Given this list of marker genes CENPH, WASF1, EBF2, GNS, CXCR4, ATXN3, PLPPR1, MAP4, DENND4C, PIK3R3, MACF1, ZFAND4, SCAI, ZEB1, BBS5, EZR, FBXO22, IFT81, GPAM, NNT, TMEM245, ZNF658, MAP3K2, HERC4, ZNF711, TOP2B, INHBB, ADAMTS5, MSL2, SPOPL, TNRC6B, PTPN12, VEZT, NSD2, DNAJC27, PDS5B (PDS5 cohesin associated factor B), SLC4A4, SOX9, GPR137B, ANGEL2, SLCO4C1, KLF9, TRUB1, ALS2, ITPRID2, TBL1XR1, NEXMIF, ZFHX4, KANSL1L, EGFL8, XPO4, RNF168, SOWAHC, TRAPPC1, PCNA, SGIP1, DSC2, NTN4, CNTN1, NRK, VPS13C, ZNF681, LRRTM3, SLC2A13, MTF1, RAB22A, MPZL2, ZNF333, TSTD2, TSPAN2, TEAD1, LEPROT, TBP, PHIP, ARHGAP21, MYO5A, ARK2N (arkadia (RNF111) N-terminal like PKA signaling regulator 2N), MMAB, ZFX, NHLRC2, MTX3, FNIP2, TRPM7, TAOK1, RSBN1, MSI1, ATXN7, PCBP1, PI4KB, RBFOX1, WDR47, VMA21, LTBP1, ANKRD55, ZCCHC10, PGM2L1, ARHGAP6, RNF19A, TPR, FERMT2, PIAS2 (protein inhibitor of activated STAT 2), CAVIN4, TGFBR3, ARID4A, NEMF, KANSL1, LPP, ENOPH1, STK39, FBXW7, ADGRB3, RNPS1, MED28, DMD, ENTPD1, ENPP2, INO80D, ARL8B, ADSS2, UBE2G1, ATL1, ZBTB44, PSIP1, CD47, OPRM1, LINC02801, PHC3, DYNC1LI2, GPR63, JAKMIP3, ADAM10, ZFPM2, PCGF5, FAM149B1, KCNC1, RPGRIP1L, PIK3CB, IPMK, IQCJ-SCHIP1, HTR5A, PDE7B, CEP85L, KLHL15, ZNF260, PAG1, DDHD1, PPP6R3, CALM1, PAK2, GEMIN5, TRAPPC8, RAB31, SPINK7, ATRNL1, SLC44A5, ZNF229, IREB2, UQCC6, PLAGL1, PPM1D, UGT3A1, PIP4K2A, PCDH7, NEURL3, SEC62, TXNRD1 (NCBI Gene Id 7296), SPRED1 (NCBI Gene Id 161742), NEK7, ZDHHC21, MEF2A, PARP16, B3GLCT, USP48, NUDT12, ONECUT2, TRMT5, RNF14, COMMD3-BMI1, CPNE8, HNRNPUL2, TP53BP1, RAB27B, TNPO1, DIDO1, C1orf131, TDG, STRBP, SOCS6, CXXC4, G3BP2, KIF2A, ZFYVE28 (zinc finger FYVE-type containing 28), TAB2, HAPLN1, INTS15, IKZF2, TNRC18, RAD23A, HLTF, DKK3, SRSF11, HACE1, GTF2A1 (general transcription factor IIA subunit 1), ZPLD1, HERC1, MAFB (NCBI Gene Id 9935), GFRA1, SLC25A24, CCDC186, SP3, TTC39B, ZNF148, UTP23, CNBP, CELSR1, CHCHD7, SYNDIG1L, PCDH11X, DTD2 (D-aminoacyl-tRNA deacylase 2), PIKFYVE, U2SURP, MPHOSPH9, ZNF91, PCBP4, XRN2, ESYT2, SERBP1, FOXJ3, FTHL17, ZNF275, MIER3, HYPK, DDX3X, PIK3R1, APOL6, ETNK1, BCOR, PDE10A (phosphodiesterase 10A), OTX2, CCL28, ZNF280C, PCLO, USP38, GTF2IRD2B, ATP11C, GTF2IRD2, DR1, CNOT6L, B3GAT1, FTO, POU4F1, BOLL, ACVR1C, ZNF713, RGS3, USP31, APELA, PLEKHB2, RNF2, CDK13, UBR2, HS3ST3A1, IKBIP, PTBP3, MED4, ATXN1 (NCBI Gene Id 7912), RPP30, USP33, CSDE1 (NCBI Gene Id 7812), CNTN4 (NCBI Gene Id 53943), CUL3, ELAVL1, TCF20, GADD45A, ZBTB14, SLC1A3, AFG2A, CLASP2, PTEN, MEX3D, ATF2, KDELR3, B4GALT6, OTULINL, NR3C2, TET1, TSPAN16, ADAM22, C3orf70, EDEM3, ZDBF2, ABHD6, MFAP3L, PIK3CG, LATS1, ZBTB41, GCSAML, NAV3, SNRPD1, EPC1, PIGN, DSG2 (NCBI Gene Id 1829), NF1, MINDY2, PHF3, ANKRD11, RAD51AP1, ITGAV, TLNRD1, REST, SESN3, EVI5, WAPL, PCGF3, ADPRH, PAIP1, FAM3C, CCNYL1 (NCBI Gene Id 151195), HLF, CALB1, SUB1, ARPP19, GNB2, SRCIN1, SDE2, KMT2D, PABPC5, SERINC5, RUFY2, TOP2A, KBTBD8, ATRX, CSK, SMAD4, ACYP2, BTF3, CCAR1, SCHIP1, MYEF2, WASHC3, CTTNBP2, TTPA, SULT1C4, KLHL28, HACD3, JAKMIP2, PLCH1, NFAT5, ZYG11B, GALNT1, TMEM169, PCBP2, ZMYND19, TMED7, RPS6KB1, BMPR2, MAP7, BRWD1, GABRB1 (gamma-aminobutyric acid type A receptor subunit beta1), ZNF264, ZC3H12C, SKIL, BEX2, CFAP418, P3R3URF-PIK3R3, FAM76A, FGG, GUCY1A1, PMS1, ACKR3, PBX2 (NCBI Gene Id 5089), NUAK1, ST18, ADIPOQ, SGCZ, SERTAD2, ZNF281, LUC7L2, OSM, DGKH, SAMD8, TMED4, VASP, ZNF569, FLI1, NDUFC2-KCTD14, SPIRE1, TAF9B, EHMT1, CNTNAP2, QKI, CAMTA1, CDC42BPB, SMNDC1, PURB, TFRC, OTUD6B, TPBG, MMP2, N4BP2L1, MECP2, CDC14A, GABPB1, ERBIN, CDYL, EIF4E, ELK4, GABRG1, SV2B, SLC25A36, CNEP1R1, PNPLA4, OSBPL8, MOB1B, AMPH, FOXO3, TET2, TMEM33, MEX3C, SPIN4, GPC4, TM9SF2, THUMPD1, MCC, LYRM7 (LYR motif containing 7), TENT4B, ADAMTSL3, FZD3, GPR85, PPM1B, WDR17, VPS37A, SCML1, PHF6 (PHD finger protein 6), RNF38, HECTD2, RAPGEF5, GNAO1, CREB5, PEX13, CDK6 (NCBI Gene Id 1021), WDTC1, GKAP1 (G kinase anchoring protein 1), TMEM236, ATP2A2, PIAS1, PTBP2, ZBTB20, KAZN (kazrin, periplakin interacting protein), ACVR2B, STAM2, GRIA3, ZFHX3, PAPOLA, EIF1, UGGT1, STXBP5, COX15, ZNF484, PRRC1, RNF207, SLC26A4, CFHR5, C4orf51, DCC (DCC netrin 1 receptor), FZD4, MYO1B, TRMT10A, GEMIN2, SREK1, ATF7IP2, BRWD3, CSTF3, PHF20L1, SLC6A11 (solute carrier family 6 member 11), CDCA4, ALKBH5, PPP3R1, TP53INP1, CPNE3, RAPH1, GPR22, ZFR, ARL6IP1 (ADP ribosylation factor like GTPase 6 interacting protein 1), CHST14 (carbohydrate sulfotransferase 14), ADH5, here is a description of the gene set: Genes predicted to be targets of miRBase v22 microRNA hsa-miR-548bc in miRDB v6.0 with MirTarget v4 prediction scores > 80 (high confidence targets). from publication Chen Y, Wang X (PMID 31504780) Human Gene Set: MIR548BC studied in species Homo sapiens